The following is a description of a gene set: The process in which sister chromatids are physically detached from each other during mitosis. Mouse Gene Set: GOBP_MITOTIC_SISTER_CHROMATID_SEPARATION species: Mus musculus, and this is the list of marker genes: Mad2l1bp, Psmg2, Ndc80, Ttk, Cul3, Anapc5, Ube2c, Khdc3, Ncaph2, Ppp2r1a, Kntc1, Ska3, Gen1, Cdc23, Klhl22, Aurkb, Zwilch, Zfp207, Fbxo5, Ccnb1, Cdca8, Spc25, Bub1, Knl1, Ska1, Anapc7, Mad1l1, Anapc11, Dusp1, Bub3 (NCBI Gene Id 97366), Anapc15-ps, Trip13, Spc24, Zw10, Anapc15, Tpr, Haspin, Nuf2, Prpf4b, Mad2l1, Cdc20, Dis3l2, Bub1b, Cep192, Prap1, Pcid2, Nsmce2, Rad21 (NCBI Gene Id 19357), Cdc16, Ik, Ccnb1-ps, Tex14, Atm, Cenpe, Apc, Birc5, Incenp, Plk1, Lcmt1 (NCBI Gene Id 30949), Spdl1, Cdk5rap2, Dync1li1 (NCBI Gene Id 93741), Xrcc3, Rb1, Zwint, Usp44, Arhgap33os